The following is a description of a gene set: studied in species Homo sapiens Reactome Pathway: MET receptor recycling Activated MET receptor is subject to recycling from the plasma membrane through the endosomal compartment and back to the plasma membrane. In the recycling process, activated MET receptor is endocytosed, and the GGA3 protein directs it, via a largely unknown mechanism, through the RAB4 positive endosomal compartments back to the plasma membrane. Endosomal signaling by MET during the recycling process appears to play an important role in sustained activation of ERK1/ERK2 (MAPK3/MAPK1) and STAT3 downstream of MET. part of: Signaling by MET, and this is the list of marker genes: ARF6, GAB1, GRB2, RAB4B, RAB4A (NCBI Gene Id 5867), CRKL, CRK, HGF, GGA3, MET